Given this list of marker genes IRF3, TLR8, IRF7 (NCBI Gene Id 3665), TLR3, TNFRSF11A, RIGI, IFIH1, MR1 (major histocompatibility complex, class I-related), MAVS, TLR7, here is a description of the gene set: Human Gene Set: WP_MRNA_VACCINE_ACTIVATION_OF_DENDRITIC_CELL_AND_INDUCTION_OF_IFN1 mRNA vaccine activation of dendritic cell and induction of IFN-1 species: Homo sapiens